The following is a description of a gene set: Mouse Gene Set: REACTOME_RHO_GTPASES_ACTIVATE_WASPS_AND_WAVES RHO GTPases Activate WASPs and WAVEs studied in species Mus musculus, and this is the list of marker genes: Abi2, Arpc1b, Actr3, Nckap1, Grb2, Arpc3 (actin related protein 2/3 complex, subunit 3), Arpc4, Mapk1, Nckipsd, Cyfip2, Brk1, Wipf1, Arpc5, Wasf3, Mapk3, Arpc2, Btk (NCBI Gene Id 215271, Bruton agammaglobulinemia tyrosine kinase), Arpc1a, Rac1, Ptk2, Wasf2, Wasf1, Actb, Cdc42, Abi1, Baiap2, Cyfip1, Nck1, Abl1, Wipf3, Actr2, Actg1, Nckap1l